Given this list of marker genes PCSK1, GNAQ, SLC5A1 (NCBI Gene Id 6523), GCG, SLC2A2, here is a description of the gene set: studied in species Homo sapiens Human Gene Set: WP_GLP1_SECRETION_FROM_INTESTINE_TO_PORTAL_VEIN GLP-1 secretion from intestine to portal vein